Given this list of marker genes CAMK2A, FGG, RAF1, MAP3K11, FN1, RAP1A, CAMK2D, MAPK3, SRC, ITGB3, RAP1B, TLN1 (talin 1), MAPK1, NRAS, CNKSR1, KSR1, ARRB1, JAK2, MAP2K2, BRAP, CSK, CNKSR2, MAP2K1, PHB1, KRAS, MARK3, PEBP1, BRAF, FGA, YWHAB, IQGAP1, KSR2, VWF, CAMK2B, FGB, ITGA2B (integrin subunit alpha 2b), CALM1, HRAS, ARAF, ARRB2, ACTG1, CAMK2G, APBB1IP, VCL, ACTB, here is a description of the gene set: studied in species Homo sapiens Signaling by moderate kinase activity BRAF mutants Human Gene Set: REACTOME_SIGNALING_BY_MODERATE_KINASE_ACTIVITY_BRAF_MUTANTS